The following is a description of a gene set: Pathway Definition from KEGG: HRAS* -> RAF -> MEK -> ERK -> MSK1 -> MYC Human Gene Set: KEGG_MEDICUS_VARIANT_HRAS_OVEREXPRESSION_TO_ERK_SIGNALING_PATHWAY species: Homo sapiens HRAS-overexpression to ERK signaling pathway. Pathway ID: N00077. Pathway type: Variant. Pathway class: nt06265 Bladder cancer., and this is the list of marker genes: MAPK3, MAP2K2, HRAS, MAP2K1, ARAF, MYC, RPS6KA5, BRAF, RAF1, MAPK1